The following is a description of a gene set: Mouse Gene Set: GOMF_HISTONE_H4K20_MONOMETHYLTRANSFERASE_ACTIVITY Catalysis of the reaction: L-lysyl20- + S-adenosyl-L-methionine = H+ + N6-methyl-L-lysyl20- + S-adenosyl-L-homocysteine. This reaction is the addition of a methyl group to the unmethylated lysine residue at position 20 of histone H4, producing histone H4K20me. studied in species Mus musculus, and this is the list of marker genes: Kmt5a, Kmt5b, Kmt5c, Setd4, Prdm9, Prdm6